Given this list of marker genes HSPB8, IMPDH2, MFN2, HSPB1, NR4A2, GCH1, here is a description of the gene set: Paresis of extensor muscles of the big toe species: Homo sapiens Human Gene Set: HP_PARESIS_OF_EXTENSOR_MUSCLES_OF_THE_BIG_TOE